The following is a description of a gene set: Mouse Gene Set: REACTOME_GASTRIN_CREB_SIGNALLING_PATHWAY_VIA_PKC_AND_MAPK studied in species Mus musculus Gastrin-CREB signalling pathway via PKC and MAPK, and this is the list of marker genes: Mapk7 (NCBI Gene Id 23939), Hbegf, Grb2, Sos1, Hras, Cckbr, Gast, Mapk3, Rps6ka3, Rps6ka2, Rps6ka1, Kras, Mapk1, Egfr, Mmp3, Creb1